The following is a description of a gene set: Human Gene Set: HP_PULMONIC_REGURGITATION Pulmonic regurgitation The retrograde (backwards) flow of blood through the pulmonary valve into the right ventricle during diastole. studied in species Homo sapiens, and this is the list of marker genes: TERT, FAM13A, SFTPA1, PARN, ATP11A, GNPTAB, KIF20A, ADA, ARSB, DNAL1, COL1A2, TERC, FOXF1, ABCA3, SFTPA2, ADAMTS19, MUC5B, FLNA, DPP9, INVS, RTEL1, DSP, EFEMP2, COL1A1, SFTPC, LEMD2, STN1